Given this list of marker genes CACNG3, OPRM1, CACNG7, PATE4, CACNG4, MINK1, CACNG8, CRHBP, LYNX1, DAPK1, PRRT1, PSCA, SHISA7, CRH, CACNG5, CNIH2, SLURP2, CACNG2, CNIH3, here is a description of the gene set: Human Gene Set: GOBP_REGULATION_OF_NEUROTRANSMITTER_RECEPTOR_ACTIVITY Any process that modulates the frequency, rate or extent of neurotransmitter receptor activity. Modulation may be via an effect on ligand affinity, or effector function such as ion selectivity or pore opening/closing in ionotropic receptors. species: Homo sapiens